The following is a description of a gene set: Human Gene Set: GSE13485_DAY3_VS_DAY21_YF17D_VACCINE_PBMC_UP The immune responses generated by YF-17D by profiling genes in 25 vaccine recipients were accessed at days 1, 3, 7, and 21 post-vaccination compared to pre-vaccination in PBMCs. The immune responses generated by YF-17D by profiling genes in 25 vaccine recipients were accessed at days 1, 3, 7, and 21 post-vaccination compared to pre-vaccination in PBMCs. studied in species Homo sapiens Genes up-regulated in comparison of unstimulated peripheral blood mononuclear cells (PBMC) 3 days after stimulation with YF17D vaccine versus PBMC 21 days after the stimulation. from publication Querec TD, Akondy RS, Lee EK, Cao W, Nakaya HI, Teuwen D, Pirani A, Gernert K, Deng J, Marzolf B, Kennedy K, Wu H, Bennouna S, Oluoch H, Miller J, Vencio RZ, Mulligan M, Aderem A, Ahmed R, Pulendran B (PMID 19029902), and this is the list of marker genes: MEF2D, NBEAL2, CKAP4, ATXN1L, MNT, ZBTB10, SLC25A28, ULK1, SNRPA1, SLC24A4, FASTKD5, NXF1, CUX1, UBAP2L, SHFL, RNF169, AMT, TET3, CLIP2, TFE3, NCOR2, TBC1D8, ZNF562, SNN, PITPNA, PCCA, UPP1, EBLN2, HAUS8, PHLPP1, IRAK1, VSIG10L (NCBI Gene Id 147645), USP3, RFPL3S, NPEPL1, AKAP8, KSR1, TFRC, TRIM8, SERPING1, RNASEH1, TIAL1, HIF1A, HMGXB4, SIK1, ELMO2, WASL, BRAP, SEC31A, ATP2C1, METRNL, TNFAIP3, SLC11A2, GRB2, APOBEC3A, ZNF805, ADAR, MASTL, VDR, SFPQ, SUSD6, RMC1, WARS1, BAP1, TIMM44, NKIRAS2, CAPN2, MYO19, MAN2A2, RIN3, BCL2L2, FHIP2A, IQSEC1, EMILIN2, EPSTI1, PIWIL4, CCDC69, RIPK1, TAOK3, PARP12, SRSF4, MAPKAP1, POLR3E, ZNF317, SH2B3, ABL1, SEPTIN7P2, GUSBP3, ACACA, SPNS1, RRN3P3, PIK3R5, RNF10, KIAA0930 (NCBI Gene Id 50610), AREG (amphiregulin), RELA, NAPG, MDM4, TENT4A, SPATA2 (NCBI Gene Id 9825), ODR4, OAS2, SPATS2L, DVL3 (NCBI Gene Id 1857), EIF2AK2, GUSB, LPP, SAMD4A, DENND1A, DCUN1D2, KIAA0513, FXYD6, DNAJC4, NTAN1, FOXK2, PWWP2B, C8orf33, IFIT3, FBXO6, SLC33A1, CTSL, RIMS3, MED6, CLCN6, MAP3K2, MRGBP, LILRB1, PAXIP1, PML, ST3GAL5, OAS3, ZNF746, VPS54 (NCBI Gene Id 51542), TENT5A, HERC6, CRK, EXT1, EIF2AK4, VPS37B, DSTYK, LAP3 (NCBI Gene Id 5186), MKNK1, SAR1A, SRGAP2C, ZNF440, BLTP3A, TNFRSF1B, IRF8, SUSD1 (NCBI Gene Id 64420), HIRA, KIF13A, FGD6, VPS11, FCHSD2 (FCH and double SH3 domains 2), PGS1, ZMIZ1, ATP2A2, SCAF4, MERTK, GOSR2, FNIP2, CORO7, FLT1, FAM209B, FMNL1, GTPBP1, USP30, ETV6, SCO2, LILRA1, HERC5, IFI44, TNS3, CCNK, ZDHHC7, PARP6, DIS3, RNF187, ARHGAP31, INVS (NCBI Gene Id 8014), SCARB2, MX1, ELF4, CMPK2, RCC2, SMAD7, AGPAT3, FMNL2, LENG8, BRAF, OGFOD3, RGL1, ZNF516